Given this list of marker genes Slc30a10, Mmgt2, Hrh1, Atp2c2, Slc39a8, Trpm2, Slc41a2, Ryr2, Atp2c1, Tmem165, Slc11a2, Slc39a14, Slc11a1, here is a description of the gene set: Mouse Gene Set: GOBP_MANGANESE_ION_TRANSPORT The directed movement of manganese (Mn) ions into, out of or within a cell, or between cells, by means of some agent such as a transporter or pore. studied in species Mus musculus